The following is a description of a gene set: Neighborhood of BAG5 Neighborhood of BAG5 BCL2-associated athanogene 5 in the GCM expression compendium species: Homo sapiens Human Gene Set: GCM_BAG5, and this is the list of marker genes: KLHDC2, GPR153, DYNC1I2, APMAP, MAEA, MED23, FAM168B, NAGLU, TAB2, ENSG00000291228 (novel transcript), C1orf43, PRRC2C, BAG5, KIAA1191, UBQLN2, SPTLC1, YTHDF3, UBE2K, FN3KRP, ACTR10, RMDN3, NAPG, VPS52, SETD3, G3BP2, RAB14, USP33, XIAP, MPC1, JKAMP, SACM1L, ZNF644, FBXO9, STARD7, ELP1 (elongator acetyltransferase complex subunit 1), TMEM50B, SAP130, HECTD1